Given this list of marker genes HIC1, ANKRD1, ZNHIT1, SMARCA4, RPL37, TP73, MIR186, TP53BP1, RPL23, RPS7 (ribosomal protein S7), ING4, CDKN2A, EEF1E1, ATR, PML, CHD5, RPS20, PLA2R1, RPS15, MSX1, CDK5RAP3, RPL26, PYHIN1, PPP1R15A, MYC, UBB, PMAIP1, ZNF385A, RPL11, DDX5, HEXIM1, EIF5A, ATM, SPRED2, SPRED1, DVL2, here is a description of the gene set: species: Homo sapiens Human Gene Set: GOBP_POSITIVE_REGULATION_OF_SIGNAL_TRANSDUCTION_BY_P53_CLASS_MEDIATOR Any process that activates or increases the frequency, rate or extent of signal transduction by p53 class mediator.